The following is a description of a gene set: The lipid bilayer surrounding any of the thin, flattened compartments that form the central portion of the Golgi complex. Human Gene Set: GOCC_GOLGI_CISTERNA_MEMBRANE species: Homo sapiens, and this is the list of marker genes: GOLPH3L, FUT4, GOLIM4, GOLGA8Q (NCBI Gene Id 727909), CSGALNACT1, INPP5E, B4GALT7, NSG2, GOLGA8B, B4GALT2, GAL3ST2, PSENEN, GOLGA8A, UXS1, NAGPA, GOLGA6A (golgin A6 family member A), FUT3, GOLGA8K, TMEM115, B4GALT1, GOLGA8CP, B4GALT3, GOLGA6C, TMED2, ATL1, GOLGA8M, GOLGA8IP, GOLGA8J, MOB4, GOLGA6D, ST3GAL1, APH1A, GOLPH3, B4GALT6, FUT7, GOLGA8DP, GALNT2, GPR89B, RAB21, GPR89A, GOLGA8O, FUT1, FUT2, GOLGA8H, SORT1, GAL3ST3, GALNT1, GOLGA8R, ABO, TMEM87A (NCBI Gene Id 25963), ST3GAL4, BCAP31, GGTA1 (glycoprotein alpha-galactosyltransferase 1 (inactive)), CHSY1, CHSY3, ST3GAL2, PITPNM1, GALNT3, ST3GAL3, TMEM87B, TMED3, A3GALT2, FUT6, NSG1, CHPF2, ASAP2, ZDHHC14, HACE1, GOLGA2, B4GALT5, FUT5, COG3, SLC30A5, SAR1B, B4GALNT3, SCFD1, SAR1A, ST6GAL2 (NCBI Gene Id 84620), GAL3ST4, B4GALNT4, ATP2C1 (ATPase secretory pathway Ca2+ transporting 1), B3GALT6, GOLGA8T, GOLGA8N, CHPF, SLC30A7, GOLGA8S, FUT8, CANT1, GOLGA3, CSGALNACT2 (chondroitin sulfate N-acetylgalactosaminyltransferase 2), ST6GAL1 (NCBI Gene Id 6480), GOLGA6B